The following is a description of a gene set: species: Homo sapiens Human Gene Set: GAVISH_3CA_METAPROGRAM_FIBROBLASTS_MHC_II from publication Gavish A, Tyler M, Greenwald AC, Hoefflin R, Simkin D, Tschernichovsky R, Galili Darnell N, Somech E, Barbolin C, Antman T, Kovarsky D, Barrett T, Gonzalez Castro LN, Halder D, Chanoch-Myers R, Laffy J, Mints M, Wider A, Tal R, Spitzer A, Hara T, Raitses-Gurevich M, Stossel C, Golan T, Tirosh A, Suvà ML, Puram SV, Tirosh I (PMID 37258682) In this study, an extensive analysis was conducted to define meta-programs (MPs) capturing intra-tumor heterogeneity across a spectrum of tumor types. The approach utilized non-negative matrix factorization (NMF) to analyze each cell type separately within individual tumor samples. This involved the analysis of malignant cells, macrophages, fibroblasts, endothelial cells, epithelial cells, T-cells, and B-cells. NMF was executed with varying parameter values (K=4, 5, 6, 7, 8, 9), thereby generating 39 programs for each cell type per sample. Each NMF program was summarized by the top genes based on NMF coefficients.\nRobust MPs were then delineated for each cell type using a set of stringent criteria, including recurrence within the same tumor, similarity to programs in other tumors, and non-redundancy within a tumor. Subsequently, these robust NMF programs were clustered (per cell type) based on Jaccard similarity, leading to the identification of MPs associated with each cell type.\nTo enhance the quality of the MPs, a refinement steps were undertaken, involving the removal of MPs suspected of reflecting low-quality data (with an overrepresentation of ribosomal proteins or mitochondrial-encoded genes), single-study inclusion, or similarity to miss-annotated cell types. Genes upregulated in subsets of cells of a given type within various tumors, and this is the list of marker genes: OCIAD2, AP1S2, CRYAB, LGI4, SEMA3B, FABP5, PMEPA1, NES, HLA-DRB5 (major histocompatibility complex, class II, DR beta 5), ITGB8, TSPAN15, PTN, STMN1, TGFBI, HLA-DPB1, HLA-DRB1, SORBS2, PLP1, HLA-DRA, GPC1, ENDOD1, VWA1, GPM6B, CLU, FAM107B, S100B, TMEM176B, FXYD1, COL8A1, HLA-DPA1, MAP1B, HLA-DMA, RCAN1, RDX, HBEGF, FSTL3, CD9 (NCBI Gene Id 928), PDLIM4, ARHGAP15, CD74, CTNNAL1, PDGFA, RASSF4, MEF2C, ALDH1A1, SLC22A17, IGFBP5, MARCKSL1 (MARCKS like 1), PAPPA, SPP1